The following is a description of a gene set: Binding to a light intermediate chain of the dynein complex. Human Gene Set: GOMF_DYNEIN_LIGHT_INTERMEDIATE_CHAIN_BINDING species: Homo sapiens, and this is the list of marker genes: DNAH11, CCDC88B, DNHD1, CCDC88C, DNAH17, DNAH14, DNAH7, RAB11A, HOOK3, HOOK1, RILP, DNAH2, DNAH1, DYNC2H1, DYNC1H1, HOOK2, DNAH6, DNAH5, BICD2, CCDC88A, RILPL1 (Rab interacting lysosomal protein like 1), DNAH10, DNAH8 (NCBI Gene Id 90022), DNAH3, DNAH12 (NCBI Gene Id 8679), RAB11FIP3, RILPL2 (NCBI Gene Id 196383), DNAH9